Given this list of marker genes MIR149, FGF18, CXCL13, MIR424, MIR15A (microRNA 15a), FGF1, MIR16-1, FGF2, FGF4, FGF16, here is a description of the gene set: studied in species Homo sapiens Any process that modulates the frequency, rate or extent of cell chemotaxis to fibroblast growth factor. Human Gene Set: GOBP_REGULATION_OF_CELL_CHEMOTAXIS_TO_FIBROBLAST_GROWTH_FACTOR